Given this list of marker genes PLA2G10, NDRG1, NMI, POLG2, DOP1A, HCAR2, TRIM14, GBP4 (NCBI Gene Id 115361), RBM43, ZNF490, GDA, CCR1, APOBEC3B, MTG1, MB21D2, LFNG, TRAF5, PLEKHM1, CCNJ, SAMHD1, ATP7A, RAB3IL1, GBP7, CSGALNACT2, H2AC25, IRF9, RBCK1, NSD2, AMACR, DR1, IKZF2, NTAQ1, PPP6R3, CAMKK1, ATP23, SLFN13, BMF (NCBI Gene Id 90427), DNAAF10, PPP1R3D, LAPTM4B, DCUN1D1, PLAAT5, GCNT2, KIAA0040 (NCBI Gene Id 9674), AHR, ZBTB5, ZSCAN2, TNFSF10, FAM174A, ZNF141, NAMPT, WDHD1 (WD repeat and HMG-box DNA binding protein 1), PSMA3, LHX2, GPR18, PMVK, NAA25, RIC8A, TAGAP, IFITM3, TCEANC2, CASP7, NSUN4, DENR, TRPC4, ZYX, CHSY1, DEXI, P2RY14, STAT2, CIITA, KRTCAP3, BATF3, TIGAR, TNFRSF1A (NCBI Gene Id 8077), BST1, DUSP9, DPF3, PAQR3, NPPA, RNF34, CARD6 (caspase recruitment domain family member 6), ZBP1, PSMB9, STK38L, LYPD2, TPPP3, UBTD1, ZNF398, FAM217B (NCBI Gene Id 63939), MBD4, C9orf85, NGDN, PMEPA1, ALLC, SLC5A6, PTPDC1, SLC26A2, SPIN4, BATF2, TAPBPL (TAP binding protein like), MT1E, SGCB, PPA1, ABRAXAS1, MSRB2, FAM241A, PNPO, PLEKHF1, NLRC5, GRM7, C19orf12 (NCBI Gene Id 83636), GOLGA3, STAT3, BMP2K, NOC4L, ASTE1, RAP2C, RNF217, RAB19, TAF4B (NCBI Gene Id 6875), UGT2B15, STING1, ZNF446, PARP3, FOXP2, PTPN2, IKZF4, NIPSNAP3A, TRAF3IP2, RAPGEF6, OPN3, C8orf33, SNRPD3, PNP, RNF114 (NCBI Gene Id 55905), AMN1, CEMIP2, SLFN12, IL10RA, ADAR, POLR1F, CRYAA, RAB9A, SPHK1, PARP14, GEMIN6, KSR1, CALHM6, NAAA (N-acylethanolamine acid amidase), GPAT3 (glycerol-3-phosphate acyltransferase 3), F3, RAMP3, VGLL4, CD274, PAK1, ZFP14, MAJIN, NUAK2, DCLRE1B, LEFTY1, ZNF365, TRIM34, CDC42SE2, MAFK, CHCT1, DAXX, CXCL11, COL5A3, AUH, CALHM5, ADAMTS16 (NCBI Gene Id 170690), EXTL3, ZNF608, KRTAP12-2, FCGR3A, PSME1, PLOD3, GADD45G, SLAMF8, H3C14, KYAT3, ZNF287, KLF2, GPR146 (G protein-coupled receptor 146), STAT1 (signal transducer and activator of transcription 1), BRME1, ATF3, RAI14, CNIH2, BLOC1S6, TAP1, OR2S2, NOD1 (nucleotide binding oligomerization domain containing 1), PKIB, PTPN1, INPP5B, ARID4A, STX7, NABP1, here is a description of the gene set: studied in species Homo sapiens Human Gene Set: GSE36009_UNSTIM_VS_LPS_STIM_DC_UP Genes up-regulated in dendritic cells: control versus LPS. Nlrp10-deficient mice have a profound defect in helper T cell-driven immune responses. T cell priming is impaired due to a defect in the emigration of a dendritic cells from inflamed tissue and antigen transport to draining lymph nodes. DC chemotaxis to CCR7-dependent and independent ligands is intact in the absence of Nlrp10. Therefore to identify novel molecules potentially involved in Nlrp10-dependent DC function we used an unbiased gene array approach on Nlrp10-deficient BMDCs treated with or without LPS. from publication Eisenbarth SC, Williams A, Colegio OR, Meng H, Strowig T, Rongvaux A, Henao-Mejia J, Thaiss CA, Joly S, Gonzalez DG, Xu L, Zenewicz LA, Haberman AM, Elinav E, Kleinstein SH, Sutterwala FS, Flavell RA (PMID 22538615)